Given this list of marker genes LANCL3 (LanC like family member 3), SH3KBP1, ELOVL7, PAQR7, RAPGEF4, ZFP14 (NCBI Gene Id 57677), AP2A2, EPAS1, ATP8B4, SMAP2 (small ArfGAP2), APPL2, NFE2L2, RYR1, RASGRP2, SETX, HS3ST3B1 (NCBI Gene Id 9953), KCTD16, IBTK, DAP, RNF32, HPS5, NYAP1, IL21, RGCC, ABHD15, EFCAB3, PIM2, LDLR, PIK3R5, ADH1C, FNTB, EMB, SYNE1, LMTK3, KBTBD13, MBP, TCAF2, PTK6, HOXA1, TDRP, TMEM9B (TMEM9 domain family member B), ENC1, UBE2J1, TRIM40, DSE, MAP7, AFP, TGFBR3, LRRC75B, AQP11, SEMA4F, RAP2B, SLC12A7, RSU1, COA6, SNN, ARHGAP29, ATP6V0A2, ST3GAL1, AR, MIA2, PIK3CG, SLC16A10, ACVRL1, ACP3, ITGB3, SLC30A4, SPP1, TSPYL4, PDE3B, BCL2L14, CREB5, AMIGO2, PPP3R1, RGMB, POLE2, SOX5, FAM78A, LYST, MCTP2 (NCBI Gene Id 55784), GPD2, SETD4, ZHX3, CDR2, CARS1, SLC16A5 (solute carrier family 16 member 5), TRIM69, SSH3, SELENOP, KLHL14, PCYT2, PAOX, CDK10, BTLA, LYPD6B, GATD1, KREMEN1, GRAP2, EHD3, PPIC, ATXN7L3B, DUSP28, ADAMTS4, RASA3, SLC6A13, METTL9, TEX13A, CNGA1, DYRK2, GTF2I, ITK, MAX, LMO4, CTSV, XKRX, DMBT1, WFIKKN2, DUSP10, AMPD1 (NCBI Gene Id 270, adenosine monophosphate deaminase 1), CYP2S1, ADCY6, RNF150, KLRD1, CLIP1, GEMIN6, VIPR1, POU5F1, TEC (tec protein tyrosine kinase), SPICE1, VWCE, MFHAS1, IL17RA, SCML4, TXNL4B, ATP1B1, PPP2R1B, C1orf21, PDLIM4, ZNF764, SHLD1, MYO3A, PUS7L, RCN3, IKZF1, DDX25, FOXK1, ENDOG, PIK3IP1, IL1RL2, DENND2D, H2BC13, THEMIS, ABHD8, HP1BP3, ALS2CL, L3MBTL3, C2orf74, TAGLN2, WDR13, IFITM10, KLHDC1, CIMAP1A, RAB27B, CDKL1, MAP10, UBALD1, SATB1, CERS6, MYO10 (myosin X), IL2, FMOD, APP, TMEM71, RFLNB (refilin B), SEMA4A, ACSS2, PPP1R15B, AKAP12, CNN3, LAIR1, TMEM72, LDLRAP1, CFAP107, DNTT, MBOAT4, GSN, S1PR1 (sphingosine-1-phosphate receptor 1), TRPV4, FAAH, DCC, TMIE, GRAMD1A, EMC9, PDK1, DAPL1, PSD3, TMEM229B, GUCD1, PPFIA4, MFSD6, here is a description of the gene set: The transcription factor Foxp3 is usually considered the master regulator for the CD4+CD25+ species: Homo sapiens Genes up-regulated in comparison of TconvLN versus TregLN (see Fig. 1 in the paper for details). from publication Hill JA, Feuerer M, Tash K, Haxhinasto S, Perez J, Melamed R, Mathis D, Benoist C (PMID 18024188) Human Gene Set: GSE7460_TCONV_VS_TREG_LN_UP